The following is a description of a gene set: Mouse Gene Set: CUI_MACROPHAGE_IL1B_RESPONSE_DN from publication Cui A, Huang T, Li S, Ma A, Pérez JL, Sander C, Keskin DB, Wu CJ, Fraenkel E, Hacohen N (PMID 38057668) Genes negatively differentially expressed in cell type: Macrophage upon treatment with cytokine: IL-1β in mouse lymph nodes in vivo. species: Mus musculus Cytokines mediate cell-cell communication in the immune system and represent important therapeutic targets. A myriad of studies have highlighted their central role in immune function, yet we lack a global view of the cellular responses of each immune cell type to each cytokine. To address this gap, the authors created the Immune Dictionary, a compendium of single-cell transcriptomic profiles of more than 17 immune cell types in response to each of 86 cytokines (>1,400 cytokine-cell type combinations) in mouse lymph nodes in vivo. A cytokine-centric view of the dictionary revealed that most cytokines induce highly cell-type-specific responses. For example, the inflammatory cytokine interleukin-1β induces distinct gene programmes in almost every cell type. A cell-type-centric view of the dictionary identified more than 66 cytokine-driven cellular polarization states across immune cell types, including previously uncharacterized states such as an interleukin-18-induced polyfunctional natural killer cell state., and this is the list of marker genes: Rab32, Bri3, Syndig1l, Gngt2 (NCBI Gene Id 14710), Ncoa4, Lmo2, Prxl2b, Ogfrl1, Slc1a3, Ftl1, Smim1, Hpgd, Vamp5, Calm2, Tle5, Aif1, Lst1, Irf8, Helz, Rasa4, Abhd17a, Gna12, Tmcc3, Ndufa2, Vamp8, Dhrs1, Gpi1, Igkc, Ptpn18, Rgs10, Ighm, Clpb, Ptp4a3, Higd2a, Sec14l1 (SEC14-like lipid binding 1), Uqcr11, Pnrc1, Cox7a2l, Atp5me, Abi3, H2bc4, Crip1, Lmo4, Eef1a1, Fau, Pycard, Rgs3